The following is a description of a gene set: Genes predicted to be targets of miRBase v22 microRNA mmu_miR_8094 in miRDB v6.0 with MirTarget v4 prediction scores > 80 (high confidence targets). studied in species Mus musculus from publication Chen Y, Wang X (PMID 31504780) Mouse Gene Set: MIR_8094, and this is the list of marker genes: Mecp2, Nell2, Zfr (NCBI Gene Id 319369), Tfap2a, Dennd10, Fbxw2, Arhgap6, Cdc27, Saxo2, Shprh, Bmpr1a, Lce1c, Etv1, Krit1, Pdia4, Arfgef3, Larp4, Arid1a, Car8, Garre1, Cpsf6, Phf20l1, Simc1, Pik3cb, Bmp15, Nfat5, Tmtc3, Rbm33, Zfp146 (NCBI Gene Id 677248), Idh3b, Dnaaf9, Dzip1, Atxn7l3b, Foxn1, Hmgb2, Golph3l, Glcci1, Zfp292, Plagl2, Nt5c2, Zwint (NCBI Gene Id 69850), Il17a, Gria3, Ikzf2, Fndc3b, Ppp4r3b, P2ry10, Cnep1r1, Ccdc148, Pramel48, Irs4, Zfp169, Mmp13, Purb, 9330159F19Rik, Hypk, Tnrc6b, Map7, Cth, Polr3e, Eloc, Dusp6, Ryr3, Zfp62, St3gal2, Pkd2l2, Epha3, Slc39a10, Elavl2, Rbm4b, Rfxap, Ypel2, Rnf138, Pknox2, Asb1, Osbpl3, Ubxn8, Cyb5r4, Nr3c1, Kcnk10, Foxc1, Coro7, Lin54, Krtap9-3, Usp7, Plag1, Ccdc82, Mybl1, Sbno1 (NCBI Gene Id 272223), Hmgb1, Pex5, Stam, Slc2a2, Hecw2, Cga, Cacfd1, Cdk14, Tacc1, Klhl13 (NCBI Gene Id 67455), Srgap1, Rcbtb1, Zic5 (NCBI Gene Id 80626), Azi2, Esr1, 2310002L09Rik, Sectm1b, Prpf4b, Ubac2, Asxl3, Yap1, Prkce, Gpr174, 2310079G19Rik, Snap29, Zeb1, Zdhhc21 (NCBI Gene Id 68268), Prkcb, Ube2b, Slx1b, Rprd1a, Ptpn21, Slitrk1, Zeb2, Gde1